Given this list of marker genes Apbb1ip, Ctsk, Pdgfrb, Trib3, Gas1, Flot1, Ccng2, Adh1, Ralgds, Gadd45a, Neat1, Ogn, Vegfd, Cryab, Pck2, Timp3, Pccb, Calml4, Nrep, Csf1, Isg15, Rasl11b, Thbs2, Mxd4, Ccl9, Il11ra1, Cyb5r1, Lpl, Tln1, Acta2, Fah, Spp1, Serpinb9, Sfrp2, H2-M3, Tle5, Vegfc, Psmb10, Col8a1, H2-T10 (NCBI Gene Id 15024), Rab11fip5, Map4, Dab2, Pdgfra, Igf1, Ccn3, Mgp, Hypk, Myl9, Plat, Klf2, Idh1, Tpm1, Asap1 (ArfGAP with SH3 domain, ankyrin repeat and PH domain1), Naa10, Ddit3, Fzd2, Plin2, Sord, F3, Col11a1, Runx1t1, Gas2, Tgfb3, Marcks, here is a description of the gene set: The molecular mechanisms that regulate cellular differentiation during development and throughout life are complex. It is now recognized that precise patterns of differentially expressed genes ultimately direct a particular cell toward a given lineage and many of these are regulated during the earliest stages of differentiation. Using a microarray-based expression analysis, we have examined gene expression profiles during the first 24 h of 3T3-L1 adipocyte differentiation. RNA was isolated at times 0, 2, 8, 16, and 24 h following stimulation of differentiation and hybridized in duplicate to high density Affymetrix microarray gene chips containing a series of 13,179 cDNA/expressed sequence tag (EST) probe sets. Two hundred and eighty-five cDNA/ESTs were shown to have at least a fivefold change in expression levels during this time course and both hierarchical and self-organizing map clustering analysis was performed to categorize them by expression profiles. Several genes known to be regulated during this time period were confirmed and Western blot analysis of the proteins encoded by some of the identified genes revealed expression profiles similar to their mRNA counterparts. As expected, many of the genes identified have not been examined in such a critical time period during adipogenesis and may well represent novel adipogenic mediators. from publication Burton GR, Guan Y, Nagarajan R, McGehee RE Jr (PMID 12137940) Cluster 1: genes progressively down-regulated over 24 h (peak at 0 h timepoint) during differentiation of 3T3-L1 fibroblasts into adipocytes in response to adipogenic hormones. Mouse Gene Set: BURTON_ADIPOGENESIS_PEAK_AT_0HR studied in species Mus musculus